Given this list of marker genes MTMR4, SMIM15, ATP9A, DNAJC5G, TLR7, SH3TC2, PPP1R3B, TTC3, SP5, PDS5B, TMEM117, KPNA3, FCGBP, GLE1, PLA2R1, IRAK4, HSD11B1, PXDN, QPRT, FMNL3, MACROD2, TFCP2L1, ODC1, RP9, ZNF488, YWHAQ, ZFYVE26, HIPK3, FAM168A, TSPYL6, FAM170B, BTLA, MAPRE2, ZNF852, TCP1, ZC3H12B, OSR1, UCN2, NSD2, HSP90B1, RASL10A (RAS like family 10 member A), ACAD11, JADE2, NATD1, NPSR1, MMP24, here is a description of the gene set: Human Gene Set: MIR7973 Genes predicted to be targets of miRBase v22 microRNA hsa-miR-7973 in miRDB v6.0 with MirTarget v4 prediction scores > 80 (high confidence targets). studied in species Homo sapiens from publication Chen Y, Wang X (PMID 31504780)